Given this list of marker genes Pax8, Pax2, Trp63, Smo, Hnf1b, Tal1, Bmp7, Taf5l, Myc (NCBI Gene Id 17869), Tcf7l1, Taf6l, Lbh, here is a description of the gene set: studied in species Mus musculus Any process that modulates the frequency, rate or extent of somatic stem cell population maintenance. Mouse Gene Set: GOBP_REGULATION_OF_SOMATIC_STEM_CELL_POPULATION_MAINTENANCE